The following is a description of a gene set: studied in species Homo sapiens Germline mutations in the BRCA1 or BRCA2 tumor suppressor genes are implicated in up to 10% of breast cancers overall and 40% of familial breast cancers. Carriers of either BRCA1 or BRCA2 germline mutation are predisposed to hereditary breast and ovarian cancer (the HBOC syndrome), which is inherited in an autosomal dominant manner. Besides early onset breast and ovarian cancer, HBOC patients also have a modestly increased risk of developing other tumor types, including pancreatic, stomach, laryngeal, fallopian tube, and prostate cancer. The BRCA1 gene encodes a large protein of 1863 amino acids, which contains a RING finger domain at the N-terminus and two BRCT repeats at the C-terminus. The RING domain is responsible for heterodimerization with BARD1, which increases stability of BRCA1 and activates its E3 ubiquitin ligase activity. BRCA1 plays an important role in homology-directed repair of DNA double-strand breaks (DSBs). Brca1-null knockout mice die early during embryonic development and cells depleted of BRCA1 show genomic instability. Cancer mutations that affect the RING domain of BRCA1 frequently result in the inability of BRCA1 to bind to BARD1 and participate in DNA DSB response. Some mutations in the RING domain of BRCA1 were shown to affect the ubiquitin ligase activity of BRCA1, but it is uncertain if the ubiquitin ligase activity is essential for the tumor suppressor role of BRCA1. Reactome Pathway: Defective DNA double strand break response due to BRCA1 loss of function part of: Diseases of DNA Double-Strand Break Repair, and this is the list of marker genes: BRCA1, BARD1